Given this list of marker genes Gm7324, Rbmy (NCBI Gene Id 19658), Ncl, Celf4, Ncbp1, Thrap3, Snrnp70, Rbmyf1, Eif1, Cdc73, Prpf19 (NCBI Gene Id 28000), Tra2a, Clns1a, Rbmyf9, Lmntd2, Rbmyf6, Dazap1, Hmx2, Prdx6, Exosc10, Hspa8, Obi1, Rbmyf3, Prmt5, Wdr77, Rbmx, Upf3a, Cirbp, Snw1, Slirp, Dhx36, Rbm3, Slc39a5, Upf3b, Rbmxl1, Rbmxl2, Eif4a3, Prdx6b, Nup98, Adarb1, Upf1, Zfp64, Ccnb1, Celf3, Tra2b, here is a description of the gene set: Mouse Gene Set: GOBP_POSITIVE_REGULATION_OF_MRNA_PROCESSING Any process that activates or increases the frequency, rate or extent of mRNA processing. species: Mus musculus